Given this list of marker genes Dgkz, Ppm1b, Azin2, Etl4, Slc6a1, Erc1, Mmab, Dcaf7, Add2, Mtcl2, Galnt7, Csf1r, Mex3c, Ldha, Svop, Camta1 (calmodulin binding transcription activator 1), Ppp1r11, Lman2l, Atg4b, Tmem164, Metap1, Slc4a8, Golph3l, Cbfa2t3, Il6ra (interleukin 6 receptor, alpha), Ddx17, Vat1, Rmnd5a, Numbl, Fbxo30, Daam1, 4930544G11Rik, Zdhhc16, Chd1, Lgr4, Fam107a, Foxj2, Pkp4, Ppargc1b, Arid4b, Pnoc, Vamp2, Acsl4, Fut8, Dpysl4, Ago4, Pacs1, Tmem255a, Arhgap26, Itch, Serpinf2 (serine (or cysteine) peptidase inhibitor, clade F, member 2), Calcr, Cntn2, Zfp282, Ccdc85a, Zfp120, Dgkb, Sidt2, Gpr158, Mta2, Synj1, Kitl, Rras, Krtap16-1, Met, Mllt3, Jade2, Hcn3, Nav3, Nat8l (N-acetyltransferase 8-like), Mmp25, Patz1, Celf3, Vcl, Taf5, Creb3l2, Rhoh, Nrip3, Nos1, Hspb6, Asic2, Bnc2, Zmym4, Htr2c, Notch1, Trank1 (tetratricopeptide repeat and ankyrin repeat containing 1), Dcx, Lyplal1, Shkbp1, Pip5k1a, Tmem79, E2f3, Foxn2, Usf1, Sirt1 (sirtuin 1), Akap6, Mgat4a, Rtn4rl1, Tnrc6b, Unc13c, Thtpa, Zfp644, Frk, Vdr, Polq, Eml5, Atp2b4, Tppp, Rragc, Abr, Tent5a, Tmem45a2, Arhgap1, Tbc1d2b, Ppfia1, Ppp2r5a, Vwa5b2, Ing5, Car7, Tgif2, Tbl1xr1, Slc44a2, Strn3, Gmnc, Wscd2, 9930012K11Rik, Gpr165, Lef1, Ccne2, Nav1, Ttc19, Notch2, Ubl4a, Kcna6, Slc25a53, Cacna2d2, Tom1, Ppp2r3a, Gmfb, Tmed8, Acsl1, Lzts3 (NCBI Gene Id 278961), Map2k1, Lhx2, Rfx3, Pogz, Zkscan16, Ucn2, Fam76a, Tanc2, Calcb, Slc25a27, Satb2 (special AT-rich sequence binding protein 2), Scamp4, Lman1, Brpf3, Ergic1, Gpr22, Ankrd52, Rab21, Zfp281, Hexa, Pitpnc1, Cuedc1, Abcd1, Fut9 (NCBI Gene Id 14348), Srpra, Plcb1, Ltbp2, Mdm4, Scml2, Gabra3, Casp2, Osgin2, Nectin1 (nectin cell adhesion molecule 1), Ahcyl2, Rtl4, Mpp2, Dixdc1, Scn2b, Coro1c, Thumpd1, E2f5, Pdgfra, Snx12, Rps6ka4, Fam83h, Slc4a7, Snx15, Syt1 (NCBI Gene Id 20979), Mycn, Erp44, here is a description of the gene set: from publication Chen Y, Wang X (PMID 31504780) Mouse Gene Set: MIR_449C_5P Genes predicted to be targets of miRBase v22 microRNA mmu_miR_449c_5p in miRDB v6.0 with MirTarget v4 prediction scores > 80 (high confidence targets). studied in species Mus musculus